Given this list of marker genes Prph2, Ahi1, Bbs4 (NCBI Gene Id 52291), Ift140, Cdhr1, Mfsd2a, Crb1, Rom1, Nphp1, Rp1, Tmem67, Cngb1 (cyclic nucleotide gated channel beta 1), Pcare, Ift20 (intraflagellar transport 20), Nphp4, here is a description of the gene set: studied in species Mus musculus A process that is carried out at the cellular level and results in the assembly, arrangement of constituent parts, or disassembly of the outer segment of a photoreceptor cell, a sensory cell that reacts to the presence of light. The outer segment of the photoreceptor cell contains the light-absorbing materials. Mouse Gene Set: GOBP_PHOTORECEPTOR_CELL_OUTER_SEGMENT_ORGANIZATION